Given this list of marker genes CEMIP, F2R, F2RL3, P2RX7, HTT, TOR2A, PDPK1, NPSR1, AKAP6, CD4 (NCBI Gene Id 920), GPER1, CAPN3, TRPC3, P2RX1, HAP1, STIM2, SRI (sorcin), PPP3R1, P2RX5, CX3CL1, CACNB3, STAC2, CRACR2A, P2RX2, BAK1, SNCA, CXCL10 (NCBI Gene Id 3627), CXCR3, STAC3, VMP1, CASQ1, ABL1, MIR1-1 (NCBI Gene Id 406904), CD19, PPP3CC, ASPH, PLCG1, ATP2A1, APLNR, BDKRB1, PPP3CB, IL13, AKAP5, CXCL9, GRIN1, STIMATE, GSTO1, CXCL11, NIPSNAP2, G6PD, TRPC1, P2RX4, STAC, STIM1, PPP3CA, PPP3R2, ADCYAP1R1, NTSR1, P2RY6, MS4A1, CACNB2, JPH2, CAV1, LACRT, XCL1, GRM6, PLA2G1B (phospholipase A2 group IB), BAX, F2, P2RX3, THY1, DRD1, here is a description of the gene set: studied in species Homo sapiens Human Gene Set: GOBP_POSITIVE_REGULATION_OF_CALCIUM_ION_TRANSMEMBRANE_TRANSPORT Any process that activates or increases the frequency, rate or extent of calcium ion transmembrane transport.